The following is a description of a gene set: The histone H3 lysine 79 methyltransferase DOT1L/KMT4 can promote an oncogenic pattern of gene expression through binding with several MLL fusion partners found in acute leukemia. However, the normal function of DOT1L in mammalian gene regulation is poorly understood. Here we report that DOT1L recruitment is ubiquitously coupled with active transcription in diverse mammalian cell types. DOT1L preferentially occupies the proximal transcribed region of active genes, correlating with enrichment of H3K79 di- and trimethylation. Furthermore, Dot1l mutant fibroblasts lacked H3K79 di- and trimethylation at all sites examined, indicating that DOT1L is the sole enzyme responsible for these marks. Importantly, we identified chromatin immunoprecipitation (ChIP) assay conditions necessary for reliable H3K79 methylation detection. ChIP-chip tiling arrays revealed that levels of all degrees of genic H3K79 methylation correlate with mRNA abundance and dynamically respond to changes in gene activity. Conversion of H3K79 monomethylation into di- and trimethylation correlated with the transition from low- to high-level gene transcription. We also observed enrichment of H3K79 monomethylation at intergenic regions occupied by DNA-binding transcriptional activators. Our findings highlight several similarities between the patterning of H3K4 methylation and that of H3K79 methylation in mammalian chromatin, suggesting a widespread mechanism for parallel or sequential recruitment of DOT1L and MLL to genes in their normal on state. species: Mus musculus from publication Steger DJ, Lefterova MI, Ying L, Stonestrom AJ, Schupp M, Zhuo D, Vakoc AL, Kim JE, Chen J, Lazar MA, Blobel GA, Vakoc CR (PMID 18285465) Genes down-regulated during adipogenesis of 3T3-L1 cells (fibroblast). Human Gene Set: STEGER_ADIPOGENESIS_DN, and this is the list of marker genes: OGN, DLK1, OLFML3, LOX, PDLIM2, THBS2 (NCBI Gene Id 7058), CMTM3, PLA2G7, RBP1, RAB3IL1, TIMP2, MAGED2, CD44, PDPN, DPT, PLAT, CCN4, RNASE4, CAPN6, WNT5A, MMP2, TIMP3, OSR1, POSTN, FSTL1